The following is a description of a gene set: Human Gene Set: GSE3039_ALPHAALPHA_VS_ALPHABETA_CD8_TCELL_UP Genes up-regulated in T cells: CD8A versus CD8A CD8B. studied in species Homo sapiens Three innate (B1-B, NKT, CD8aaT cells) and adaptive (B2-B, CD4T, CD8abT cells) cell-types were sorted by FACS. Three biological replicates for NKT, CD4T, CD8aaT, CD8abT cells and two biological replicates for B1 and B2 cells were generated and the expression profiles were determined using Affymetrix Mu74Av2 chip. Comparisons between the sample groups allow the identification of genes differentially expressed between the innate and adaptive cell-types. from publication Yamagata T, Benoist C, Mathis D (PMID 16623764), and this is the list of marker genes: EIF2B2, IKBKE, HILPDA, PTGR1, F11R, ARL6IP4 (ADP ribosylation factor like GTPase 6 interacting protein 4), NUP93, DAB2, TATDN2, AARS1, PDPN, CPED1, HSPA1B, GTF2H5, KDELR2, TMEM214, HACD1, CTPS1, HAL, FKBP1B, POLR2F, GYS1, COMTD1, SERF1A, FAM20C, VDR, POP4, STRIP1, CCHCR1 (coiled-coil alpha-helical rod protein 1), NDUFS5, CCR5, SLC39A1, LDHA, PTGES, IER3, ATG4B, CTSV, LTC4S, UTP18, UQCRQ, ANKRD37, FABP5 (fatty acid binding protein 5), THAP4, HBEGF, OLFM1, TREM1, IL6, RNF217, GDE1, ATP5PF, NUCB2, PGLS, CCDC86, MRTO4, DIP2A, SMDT1, AP2M1 (adaptor related protein complex 2 subunit mu 1), C1R, ECHDC3, CXCL1, FAM221A, CREB5, LRP12, METRN, MT1E, ELK3, PSMB5, BHLHE40, CHST14, MRPS25, CD14, BCL2A1, ETS2, C15orf39, IGF2R, CTDSPL, KGD4, PRAF2, EPS8, TCEAL9, HSPA1A, PLAU, LGALS3, SLC35F6, MEA1, TPI1 (triosephosphate isomerase 1), NOP2, TAP2, CCN4, LXN, MTFR2, PHLDA1, SDC4, SPRY2, OSM, UPP1, TMEM183A, DHFR, SSBP4, MATN3, SNRPF, LSR, TLR2, CXCL3, SLC15A3, ATP5MK, BASP1, PPP1R14B, PCNX4, DYNC1I2, GTF2F1, CSRNP1, IL4R, GMNN, CDKN1A (cyclin dependent kinase inhibitor 1A), UQCR11, TBRG4 (NCBI Gene Id 9238), PALD1, MKKS, MAFF, LRPAP1, HDDC3, IGFBP6, CCDC115, MRPL41, ACADL, HMGA1, MT2A, HTR7, PRELID1, PRPF31, ACY1, CLTB, GPX3, BYSL, CTF1 (NCBI Gene Id 1489), SLC2A1, NXN, S100A10, RAB11A, GPI, FGD6, GPR84, JUN, ATP6AP2, EGLN3, VPS53 (NCBI Gene Id 55275), DHX32, EIF1AX, GBA1, CDK8, DCAF1, GPR171, RRBP1, CTNNB1, RPS27L, FCGR2B, CCL4, SCAMP1, MICALL2, IRF2BP2, LRATD2, TRIO, ALDOA, S100A1, MYC, PFKP, UBE2J2, SOCS3, EGR1, PTPRS (protein tyrosine phosphatase receptor type S), DCN, APRT, ESD, RAMP3, SRP19, SNX1, MCTS1 (NCBI Gene Id 28985), PFKL, H3-5, AIFM2, CDH1, GPAT3, CCDC80, PLXDC2, NIBAN2, TXN2, B3GNT7, NUPR1, CCR1, PF4, MTCH1 (NCBI Gene Id 51627), AP2S1, ELL2, PCSK4, UCK2 (NCBI Gene Id 7371), MED10, PSMD3, SNRPD1, SH3PXD2B